The following is a description of a gene set: Human Gene Set: HP_ABNORMAL_BONE_STRUCTURE studied in species Homo sapiens Abnormal bone structure Any anomaly in the composite material or the layered arrangement of the bony skeleton., and this is the list of marker genes: SLC35A2, PDLIM4, SQSTM1, STX3, MBTPS1, ADAMTSL2, VPS37D, ANKH, TAPT1, RPL10, GGCX, LRP4, RETREG1, RPL11, RECQL4, DDOST, SLC34A1, TPO, SLC4A1, FN1, FIG4, FARSB, OTX2, MMP13, HBB (NCBI Gene Id 3043), ASAH1, TBXAS1, SLC37A4, NAGLU, PMM2, TSHR, TGFBR2, LPIN2, TJP2, NPR2, ORC6, UBA2, B3GAT3, ATL3, TERC, IQCB1, FGF8, FANCI, BGN, TMEM53, PHF21A (PHD finger protein 21A), BUB1, CLDN16, GPC4, AP1S2, VAC14, NPHP4, RMRP, PLEC, NHERF1, ALG3, SRY, AEBP1, WT1, BMPER, NAE1 (NEDD8 activating enzyme E1 subunit 1), UROS, FGFR1, VDR, PRDM5, SPARC, ANTXR1, METTL5, TRAPPC10, RAB3GAP1, TBL2, FLNB, FBLN5, NAGA (alpha-N-acetylgalactosaminidase), FZD4, MED12, HSD3B7, IFT56, CHST3, ZMPSTE24, MIF, TRPV6, SLX4, TBX4, SGMS2, ALPL, ALK, GLA, GNA11, TBCE, KCNN4, CDKN2C, CDC73, NANS, GLB1, GNPAT, NEU1, POLRMT, COPB2, PEX7, B4GALT7, EXT1, KLF1, PEX2, PPIB, LRP6, SETD2, NDP, STIL, ABCC9 (ATP binding cassette subfamily C member 9), LETM1, FUT8, SOX5, CTNND2, CENPE, NUP107, SPRY4, CEACAM3, TARS1, BTNL2, PEX13, COX4I2, PPP3CA, FKBP14, MITF, APC, HSPG2, IFIH1, NDUFAF6, SC5D, FANCA, DUSP6, CHD6, SGSH, RRAS2, USP9X, ZNF668, AGA, MFSD2A, SOS1, G6PC1, ABCC6, SCN4A, KIF1A, GCLC, GEMIN4, DLK1, PROP1, TNFSF11 (NCBI Gene Id 8600), ENPP1, MMP14, GALT (NCBI Gene Id 2592), PIGG, NHLH2, TNFRSF11B, PRKACA, STN1, WNT3, SRP19, KIAA0586, BRAF, MPLKIP, BUB3, ATRX, AGPS, CCND1, GNRHR, WRN, RNF125, RUNX2, COL5A1, PEX16, FBN1, FKBP10, NFIX, RIGI, SLC4A2, SRP54, SNORD116-1, PEX14, CTC1, HERC2, TAF13, SCARB2, TRAPPC14, IL17RD, HFE, NCAPD3, DDRGK1, MAD2L2, FBXO11, HRAS, NKX3-2, SRC, CHEK2, WNT1, EHHADH, TCOF1, CYB5A, CEP290, SLC35D1, GALNS, PDGFRB, INVS, IL12RB1, PSMC3IP, ZNF408, SERPINA1, UROD, KLLN, TNFRSF11A, PHC1, CDK5RAP2, NPAP1, CPLX1, ANTXR2, FGFRL1, IKBKG, DMP1, GLI3, NLRP3, NDNF, GTF2H5, PEX10, FANCG, ALG9, KISS1R, HS6ST1, COL10A1, SARS1, RAD51 (NCBI Gene Id 5888), SLC39A14, MAGEL2, POLR1C, AKR1D1, ZSWIM7, KDELR2, LIFR, MAN2B1, KCNJ1, HAMP, FERMT3, AFF3, SOX3, CDKN1A, GPAA1, OCA2, MMEL1, TRMT10A, ASPM, GJA1, CAVIN1, WNK1 (NCBI Gene Id 9872), TNPO3, CLIP2, ALB, BMP2, RUNX1, IFT80, SEMA4D, THRB, NAA20, TBCK, CALCR, NCF1, TYROBP, PEX12, COL1A1, BMP1, GLE1, PIGL, LONP1, LAMA3, SLC11A1, MTAP, CA2, PIGY, GNPTAB, SYK, SOX9, DBR1, SLC9A3, MDM4, LZTR1, POLR3H, CLCN5, HNRNPA2B1, AIP, SLC25A4, HLA-DRB1, PRKG2, RTEL1, CLPB, CEP57, PHKB, MTTP, IL12A, ZEB2, STAT3, WDR19, MEG3, BMP6, TRPS1, SMARCAL1, TAC3, ERCC6, GORAB, MRAS, SMPD1, SOX10, MPL, ARMC5, SLC5A5, UNC45A, NDN, PAM16, KIF22 (NCBI Gene Id 728037), NSMF (NCBI Gene Id 349336), POLR3A, CEP63, GJB6 (gap junction protein beta 6), GATA4, INTU, NELFA, GNAS, ELP1, NGLY1, GTF2E2 (NCBI Gene Id 2961), IHH, TRIP11, GDF5, PROKR2, PLOD1, FANCM, LFNG, OFD1, NHP2, CTCF, SKI, DUOXA2, TMEM270, DUOX2, PEPD, CCDC141, SIM1, TRAPPC2, HBG1, PEX26, SRCAP, PYCR2, ESR2, USP8, FAM111A, IRX5, GPR35, UNC80, RNU4-2, NF1, PALB2, IFITM5, CSPP1, EFL1, KISS1, IFT140, SPIDR, XRCC2, IARS2, NPM1, PEX1, PTPN11, MCM7, ANOS1, LAMA5, CEACAM6, POLD1, PEX3, MGP, AGPAT2, EIF2AK3, HPGD, SDHD, PIGV, CYP2R1, ZNF699, PRG4, CARS1, RIN2, SLCO2A1, RNF113A, LHX3, CFTR, PIK3CD, CAV1, TMEM165, TRPV3, BMP15, FAT4, FANCL, SLC29A3, MRPS22, SLC25A24 (solute carrier family 25 member 24), PISD, PWRN1, OSTM1, MMP1, LHX4, STX16 (syntaxin 16), KL, MEN1, FANCB, SLC39A8 (solute carrier family 39 member 8), NUP37, PAPPA2, COL3A1, MIR140, SLC10A1, SPRTN, CBFB, PORCN, FLRT3, TG, GK, NR5A1, HOXA13, MLXIPL, STAT1, ADCY10, LAMB3, SLC12A1, ARSL, GNRH1 (gonadotropin releasing hormone 1), WNT7A, DPAGT1, CDH23, COL1A2, FOS, IRF5, COL5A2, CTBP1, SNRPB, BMPR1B, XYLT1, PSTPIP1, RSPO2, P4HB, COL9A3, DPM2, KIF7, ADAMTS10, NPHP1, DKC1, AMER1, BUB1B, IYD, SLC39A13, ADAMTS2, CYP19A1, DYNC2I2, MAP3K7, NSD2, AKT1, DYM, DVL1, DKK1, TAF1, GTF2I, LMNA, KNSTRN, OCRL, FANCF, TINF2, CHD7, UBE2T, CIT, SLC35B2, GTF2IRD2, BANF1, COMP, SETBP1, GTF2IRD1 (GTF2I repeat domain containing 1), HNRNPK (NCBI Gene Id 3190), DNAJC21 (DnaJ heat shock protein family (Hsp40) member C21), PTEN, FLNA, MC4R, MMP2, FXN, NOTCH3, PIK3CA, ASXL1, XYLT2, HECW2, CYP17A1, USF3, MALT1, PEX11B, ANKLE2, TENT5A, SP7, NR3C1, CYP11A1, PIGU, BAZ1B, CEP152, PARN, BRCA1, P3H1, SALL4, TACR3, TSPAN12, SPRED2, POU1F1, WARS1, CDKN1C, SBDS, BUD23, ITGB4, LMX1B, BRCA2 (NCBI Gene Id 82716), PEX6, GSTM3, PTDSS1, KDM1A, HGD, ZFPM2, ALG12, SFRP4, SLC26A2, RNU4ATAC, NFKBIA, KARS1, PLCB3, TCF4, CLCA4, AARS1 (alanyl-tRNA synthetase 1), NRAS, MSH4, MBTPS2, FBN2, TONSL, IFT52, AGK, FAH, GLIS3, CREB3L1, PROK2, B2M, COL7A1, SLC26A9, STX1A, HNRNPA1 (heterogeneous nuclear ribonucleoprotein A1), GATM, NSDHL, SDCCAG8, WWOX (NCBI Gene Id 9621), EXTL3, HNF4A, ZBTB20, BSCL2, ZFX, WDR62 (NCBI Gene Id 4181), DHCR7 (NCBI Gene Id 6589), WRAP53, PHLDB1, ELN (elastin, NCBI Gene Id 2006), DHCR24, RNU7-1, ATP6V0A2, SLC17A5, TNNC2, PIGA, TCIRG1, TXNDC15, TRAF3IP1, KIF14, DNAJC30, WDR11, TP53, CDK6, NAB2, UFSP2, IDH2, IL1RN, TYMS, POF1B, ATP7B (NCBI Gene Id 540), RRAS, CYP27B1 (NCBI Gene Id 5135), DCHS1, IDH1, PDE4D, CASR (calcium sensing receptor), HBG2, AP2S1, MTRR, RRM2B, POLE, FANCC, MIA3, LBR, SDHC, PLOD2, TMEM38B, PCCA, TET2, MAFB, ELMO2, POLG2, USP48, HHAT, TGFB1, GSC (goosecoid homeobox), RB1, TREM2, SEMA3E, TSHB, RBL2, SLC6A14, AVP, HNRNPH1, MATN3, IER3IP1, PTCH1, POLG, PHEX, DHX37, SLC9A6, WNT3A, CANT1, LRP5, MTX2, ACP5, USB1, TWNK, NOTCH2, CCDC134, PCCB, PHKG2, EIF4H, CTNS (cystinosin, lysosomal cystine transporter), DLX3, HSD17B4, SLC25A19, FGFR2, ESR1, POLR1D, TRIP13, CD96, CCN2, HGSNAT, THPO, CBS, AXIN1, ASCC3, SLC34A3, IFT122, MKRN3, HTRA1, COL11A2, SNRPN, CHRNG, HDAC6, ALDH18A1, FANCE, GUSB, PTH1R, DCC, CTDP1, CTSC, NPHP3, EED, FOXA2, ANO5, WDR35, SEC23A, WNK3, GCM2, AIFM1, FGF17, TMEM67, SOST, MAP3K1, CRIPT, ATP6V0A1, ZNF469 (zinc finger protein 469), POLR1B, ACVR1, PIGT, ATP6V0A4, SEMA5A, GLI2, KRAS, SAMD9, CEP164, CDKN2B, SEC24D, POU2AF1, RIT1 (NCBI Gene Id 6016), DLL4, SDHB, PYCR1, DCTN4, SLC34A2, SNX10, SEC23B, FEZF1, RFWD3, PYGL, VPS53, ATP7A, LEMD2, TERT, CCN6, CDKN1B, SPIB, NFATC2, SEMA3A, AGXT, RAD51C, ERCC8, EXT2, TNFSF15, ERCC2, SMARCD2, SH3PXD2B, PDE11A, SMAD3, DDR2, GPC3, VAMP7, PEX19, PHKA2, LIMK1 (LIM domain kinase 1), PUM1, SMS, CYP3A4, SCN9A, KIT, BMP4, ORC1, MGAT2, SLC2A2, SIK3 (NCBI Gene Id 80236), SNORD115-1, B3GALT6 (beta-1,3-galactosyltransferase 6), ERI1, MAP2K1, SLC10A7, HMOX1, ERCC4, FAM20C, EXOC6B, PLEKHM1, KNL1, KCNH1, BNC1, NDUFAF1, VCP, MST1 (NCBI Gene Id 4485), GFI1, INPPL1, LTBP4, PRKAR1A, NR0B1, GATA1 (GATA binding protein 1), METTL27, LEMD3 (LEM domain containing 3), GET4, DNA2, PRLR, RTL1, SERPINH1, CTSK, GBA1, STAT6, VPS35L, EDNRA, LACC1, FANCD2 (FA complementation group D2), CTNNB1, ELANE, IFT43, CYP27A1, CBL, TRIM37, SASS6, CEP135 (centrosomal protein 135), SRSF2, DYNC2H1, COG1, HLA-DQA1, NOP10, PSAP, LRRK1, FKBP6, SH3BP2, EBP, GJB2, RSPRY1, IGF1, LARS2, HJV, PEX5, TCF12, GPX4, ARL6IP6, POC1A, CCR6, PLOD3, PERP, SOS2, SLC7A7, LAMC2, SATB2, COL2A1, CSF1R (colony stimulating factor 1 receptor), NT5E, BRIP1, HLA-DQB1, PWAR1, ANAPC1, CRTAP, FSHR, NAF1, HESX1, PPARG, CLCN7, DYNC2I1, TRPV4, MCPH1, ATP8B1, RAF1, HMGA2, IL6, RFC2, ERCC3, BAAT, ASXL2, BMS1, FGF23, ALX4, RASA2, KCNJ8